The following is a description of a gene set: species: Mus musculus Reactome Pathway: Collagen chain trimerization electronically inferred by orthology from the curated human pathway part of: Collagen biosynthesis and modifying enzymes This event has been computationally inferred from an event that has been demonstrated in another species.<p>The inference is based on the homology mapping from PANTHER. Briefly, reactions for which all involved PhysicalEntities (in input, output and catalyst) have a mapped orthologue/paralogue (for complexes at least 75% of components must have a mapping) are inferred to the other species., and this is the list of marker genes: Col18a1, Col6a5, Col5a3, Col6a1, Col13a1, Col7a1, Col20a1, Col2a1, Col8a1 (NCBI Gene Id 12837), Col19a1, Col10a1, Col24a1, Col11a2, Col17a1, Col15a1, Col12a1, Col6a6, Col25a1 (NCBI Gene Id 77018), Col8a2 (collagen, type VIII, alpha 2), Col9a1